Given this list of marker genes MCM2, MCM4, BARD1, POLD4, INO80, HELB, GMNN, TICRR, LIG3, CCNE1, TK1, EXO1 (exonuclease 1), POLB, CDC34, CENPX, GEN1 (GEN1 Holliday junction 5' flap endonuclease), DBF4, ZNF365, BRCA2, CARM1, SETMAR, TONSL (NCBI Gene Id 4796), EXD2, CAMSAP3, RPA4, ZPR1, CDK2, CIZ1, POLD2, NUCKS1, WIZ, E2F7, FAM111A, PRIMPOL, POLE3 (NCBI Gene Id 54107), GMNC, POLRMT, GINS4, TIPIN, SLFN11, ATAD5, MCM7, CDC7, RAD50, MCIDAS, RFC1, ZRANB3, BLM, ORC1, PRIM2, LRWD1, METTL4 (NCBI Gene Id 64863), LIG1, E2F8, TOPBP1, RECQL, BAZ1A, WDHD1, SAMHD1, NOC3L, CCNE2, BOD1L1, RTEL1, DNAJA3 (DnaJ heat shock protein family (Hsp40) member A3), POLE2, FGFR1, ATR, DNA2, RAD51, REV3L, TRAIP, POLD3, BCL6, SMARCAL1, GINS3, PURA, POLA2, TERF1, RFC3, POLG2, RPA1, PCNA (proliferating cell nuclear antigen), MCM9, KAT7, EME1, CDK9, WDR18, FBXO5 (F-box protein 5), POLE4, TIMELESS, CDT1, DBF4B, RRM1, CDC45, MMS22L, WRN, ASF1A, POLA1, CDK2AP1, MCMBP, ZNF830, BRCA1, PARP1, ATRX, EME2, DYNLL1, MCM8, MCM10, ORC5, MCM6, POLN, ZMPSTE24, POLD1, CHRAC1, NYNRIN, MRE11, POLE, RBBP8, TERF2, ENDOG, SSBP1, RECQL5, RFC4, UPF1, RTF2, POLG, NUGGC, ETAA1, DDX11, TWNK, NBN, MGME1, MUS81, DONSON, ORC2, TEFM, PNKP, POLQ (NCBI Gene Id 29043), CDC6, AGER, CENPS, FEN1, RFWD3, ORC6 (NCBI Gene Id 23594), MCM3, DACH1, SENP2, OOEP, KHDC3L, GINS1, FANCM, RRM2B, ORC3, AICDA, RFC5, RFC2, ORC4, MCM5, WRNIP1, FBH1, PRIM1, here is a description of the gene set: Human Gene Set: GOBP_DNA_TEMPLATED_DNA_REPLICATION A DNA replication process that uses parental DNA as a template for the DNA-dependent DNA polymerases that synthesize the new strands. studied in species Homo sapiens